Given this list of marker genes MMAA, MMUT, here is a description of the gene set: studied in species Homo sapiens part of: Diseases of metabolism Reactome Pathway: Diseases of mitochondrial beta oxidation